The following is a description of a gene set: species: Mus musculus The movement of an immune cell in response to an external stimulus contributing to an inflammatory response. Mouse Gene Set: GOBP_LEUKOCYTE_CHEMOTAXIS_INVOLVED_IN_INFLAMMATORY_RESPONSE, and this is the list of marker genes: Ptn, Mdk, Alox5, Slamf8, Ninj1, Slamf1, Ffar2, Lbp